The following is a description of a gene set: studied in species Mus musculus Mouse Gene Set: GOMF_CHLORIDE_CHANNEL_REGULATOR_ACTIVITY Binds to and modulates the activity of a chloride channel., and this is the list of marker genes: Chrna7, Clcn2, Cftr, Ano9, Vti1b, Bsnd, Stx8, Nherf1, Stx7, Vamp8, Trpv1, Stx1a